The following is a description of a gene set: studied in species Mus musculus Mouse Gene Set: GOBP_REGULATION_OF_MITOCHONDRIAL_MEMBRANE_PERMEABILITY_INVOLVED_IN_APOPTOTIC_PROCESS Any regulation of mitochondrial membrane permeability that is involved in apoptotic process., and this is the list of marker genes: Them4, Gclc, Vdac2 (NCBI Gene Id 22334), Bcl2l1, Fzd9, Mul1, Siva1, Slc25a4, Bnip3l, Slc25a5, Bnip3, Slc25a31, Nol3, Bcl2l11, Tmem14a, Bloc1s2, Stpg1, Hip1r, Bax (BCL2-associated X protein), Acaa2, Ppm1k, Bok, Gsk3b, Rhot2, Chchd10, Naif1, Bid, Mpv17l, Bak1, Slc35f6, Atf2, Gsk3a, Eya2, Tmem102, Camk2a (NCBI Gene Id 98128), Zfp13, Trp53, Ier3, Rhot1, Mtch2, Atp5if1